The following is a description of a gene set: studied in species Homo sapiens Persistent pupillary membrane Human Gene Set: HP_PERSISTENT_PUPILLARY_MEMBRANE The presence of remnants of a fetal membrane that persist as strands of tissue crossing the pupil., and this is the list of marker genes: HRAS, ADAMTSL4, ATOH7, GJA1, NDP, POMT2, TRPM3 (NCBI Gene Id 80036), CPAMD8, COL18A1, FZD4